Given this list of marker genes Itprid2, Setd3, Diaph1, Myo16, Med28, Gmfg, Cacnb2, Mib2, Actn4, Hnrnpu, Tpm2, Gas2l3, Tmod4, Misp, Capg, Kcnma1, Arpc1a, Gc, Evl, Mrtfa, Eps8l3, Lsp1, Map1a, Ssh2, Wasf2, Espn, Fmnl2, Gmfb, Marcks, Myh4, Lrrc10, Mylk, Myo1b, Ezr, Myot, Map2, Pfn3, Myo3a, Dmd, Itgb1, Vasp, Tmod3, Pof1b, Scin, Twf1, Xirp2, Tns1 (NCBI Gene Id 98418), Pawr, Scnn1a, Spata32, Anln, Myoz2, Ccr5, Myh1, Pdlim4, Coro1b, Ophn1, Myo10, Gas2l1, Wipf2, Tmsb4x, Nos2, Parvg (parvin, gamma), Antxr1, Myo1h (NCBI Gene Id 67424), Enc1, Tpm3, Fhl3, Tmsb15l, Lims1, Uaca, Mybpc2, Coro6, Mical2, Sntb2, Gas2, Klhl2, Nos3, Afdn, Tnni3, Phactr4 (phosphatase and actin regulator 4), Fermt2, Ace, Syne2, Fmnl1, Tln2, Flna, Spire1, Adcy8, Dag1, Diaph2, Tagln3, Daam1, Cap1, Myh13, Nf2, Myo1g, Ipp, Dnase1, Actr2, Myh15, Ywhag, Msn, Prickle4, Fmnl3, Afap1, Sptbn5, Nebl, Ywhah, Arpc2, Mrtfb, Mical1, Tmem201 (transmembrane protein 201), Tpm3-rs7, Ino80, Lima1, Samd14, Ang2, Ermn, Ctnnal1, Gas7, Rai14, Hdac6, Tnnc1, Sptb, Dst, Kif18a, Gbp2b, Pxk, Fxyd5, Frg1, Tnni2, Tmod2, Cobl, Myh3, Myo9b, Plec, Pfn4, Msrb2, Mprip, Cald1, Add3, Capza1b, Myo5b, Flii, Myrip, Shroom1, Homer2, Fscn3, Lmod3, Akap5, Whamm, Cnn1, Parva, Ssh1, Ablim1, Phactr1, Myh7, Klhl1, Map1b, Synpo, Map1s, Flnb, Pdlim1, Fbxo25, Washc1, Camsap3, Eps8l2, Myo9a, Vash2, Ang6, Tprn, Ablim2, Hdgf, Tln1, Capza1, Spata31, Prkce, Pfn5, Myh7b, Egfr, Myh2, Tagln2, Myo19, Phactr2, Fhod3, Sntb1, Adss1, Myo7b, Msrb1, Pfn2, Ppp1r9b, Fhod1, Lmod2, Tnnc2, Rusc1, Limd2 (LIM domain containing 2), Arpc5l, Myl3, Trpc6, Ppp1r9a, Diaph3, Tpm1, Actn3, Iqgap1, Rcsd1, Cgn, Panx1, Synpo2, Anxa8, Ctnna1, Pdlim7, Pls3, Myo18a, Spef1, Was, Arpc5, Klhl17, Fscn2, Micall2, Myo1c, Cfl1, Dixdc1, Dstn, Abl1, Tulp1, Pknox2, Actr3b, Myo15a, Amotl2, Syne3, Epb41l1, Spire2, Tnnt3, Tmsb15a, Lrrk2, Cfl2, Add2, Pick1, Vil1, Svil, Plekhh2, Lmod1, Fmn1, Plekhg3, Lasp1, Triobp, Tmsb10, Ppp1r18, Myo1e, Cxcr4, Epb41, Pdlim5, Daam2, Abitram, Dbn1, Hook1, Cyfip1, P4hb, Epb41l3, Tmsb15b1 (thymosin beta 15b1), Abi3bp, Nexn, Dmtn, Espnl, Pdlim2, Wdr1, Slc6a4, Ceacam1, Cobll1, Epb41l2, Hpca, Iqgap3 (NCBI Gene Id 99678), Myo5c, Ssh3, Jmy, Limch1, Pdlim3, Tmsb15b2, Cdk5r1, Abra, Clasp2, Coro2b, Slc4a1, Impact, Wipf1, Cttn, Mical3, Enah, Snta1, Myh9, Myoz1 (myozenin 1), Eps8, Myh10, Csrp3, Gas2l2, Myh8, Ablim3, Aif1l, Arpc4, Slc6a2, Ctnna3, Phpt1, Prkn, Sptbn4, Ang (NCBI Gene Id 11727), Myh6, Add1, Kptn, Pfn1, Ang5, Shroom3, Coro2a, Actn2, Coro1a, Gipc1, Fermt1, Sntg1, Pstpip2, Mtss2, Parvb (parvin, beta), Ctnna2, Ppp1r42, Crocc, Sntg2, Bin1, Ncald, Sipa1l1, Myo1a, Hip1r, Spta1, Iqgap2, Cnn2, Kbtbd13, Flnc, Ankrd24, Phactr3, Trpm7, Myo18b, Dyrk1a, Macf1, Fmn2, Vash1, Mlph, Capzb, Gcsam, Wasl (WASP like actin nucleation promoting factor), Aqp2, Cdk5r2, S100a4, Clmn, Capza3, Abi3, Klhl20, Lcp1, Smtn, Myh14, Vinac1, Gbp2, Rdx, Ceacam2, Utrn, Klhl3, Mypn, Gjb6, Myoz3, Stk38l, Shroom4, Actn1, Lrpprc, Arpc1b, Wasf3, Cotl1, Pstpip1, Pacrg, Myl4, Ccdc88a, Eps8l1, Vps16, Hcls1, Vps18 (NCBI Gene Id 228545), Fam107a, Pls1, Myo7a, Vill, Eef2, Myo1d, Dbnl, Sptbn2, Xirp1, Aif1, Myl2, Myo3b, Tlnrd1, Shroom2, Baiap2l1, Alkbh4, Shank3, Syn1, Capza2, Nod2, Tmod1 (NCBI Gene Id 21916), Ang4, Coro7, Fgd4, Myo1f, Cap2, Trpv4, Coro1c, Sptan1, Mtss1, Tpm4, Ptk2, Avil, Syne1, Mybpc3, Palld, Gsn, Arc, Bloc1s6, Mefv, Maea, Myo6, Actr3, Tnnt2, Sptbn1, Neb, Fscn1, Fhdc1, Myo5a, Ldb3, Hip1, Inppl1, Tnni1, Myh11, Fkbp15, Cnn3, Cd2ap, Trpc5, Ttn, Marcksl1, Inf2, Tns4 (tensin 4, NCBI Gene Id 217169), Synpo2l, Wipf3, Nrap (NCBI Gene Id 18175), Tbc1d21, Luzp1 (leucine zipper protein 1), Wasf1 (WASP family, member 1), Snca, Ajuba, Shtn1, Arpc3, Vcl, Twf2, Emd, here is a description of the gene set: Mouse Gene Set: GOMF_ACTIN_BINDING species: Mus musculus Binding to monomeric or multimeric forms of actin, including actin filaments.